The following is a description of a gene set: Human Gene Set: KRIGE_RESPONSE_TO_TOSEDOSTAT_24HR_DN from publication Krige D, Needham LA, Bawden LJ, Flores N, Farmer H, Miles LE, Stone E, Callaghan J, Chandler S, Clark VL, Kirwin-Jones P, Legris V, Owen J, Patel T, Wood S, Box G, Laber D, Odedra R, Wright A, Wood LM, Eccles SA, Bone EA, Ayscough A, Drummond AH (PMID 18701491) species: Homo sapiens Genes down-regulated in HL-60 cells (acute promyelocytic leukemia, APL) after treatment with the aminopeptidase inhibitor tosedostat (CHR-2797) for 24 h. CHR-2797 is a novel metalloenzyme inhibitor that is converted into a pharmacologically active acid product (CHR-79888) inside cells. CHR-79888 is a potent inhibitor of a number of intracellular aminopeptidases, including leucine aminopeptidase. CHR-2797 exerts antiproliferative effects against a range of tumor cell lines in vitro and in vivo and shows selectivity for transformed over nontransformed cells. Its antiproliferative effects are at least 300 times more potent than the prototypical aminopeptidase inhibitor, bestatin. However, the mechanism by which inhibition of these enzymes leads to proliferative changes is not understood. Gene expression microarrays were used to profile changes in mRNA expression levels in the human promyelocytic leukemia cell line HL-60 treated with CHR-2797. This analysis showed that CHR-2797 treatment induced a transcriptional response indicative of amino acid depletion, the amino acid deprivation response, which involves up-regulation of amino acid synthetic genes, transporters, and tRNA synthetases. These changes were confirmed in other leukemic cell lines sensitive to the antiproliferative effects of CHR-2797. Furthermore, CHR-2797 treatment inhibited phosphorylation of mTOR substrates and reduced protein synthesis in HL-60 cells, both also indicative of amino acid depletion. Treatment with CHR-2797 led to an increase in the concentration of intracellular small peptides, the substrates of aminopeptidases. It is suggested that aminopeptidase inhibitors, such as CHR-2797 and bestatin, deplete sensitive tumor cells of amino acids by blocking protein recycling, and this generates an antiproliferative effect. CHR-2797 is orally bioavailable and currently undergoing phase II clinical investigation in the treatment of myeloid leukemia., and this is the list of marker genes: YY1, IKBIP, ESF1 (ESF1 nucleolar pre-rRNA processing protein homolog), TOP1MT, TSR1, BAHCC1, SPRY1, FRG1HP, DIMT1, SEC11C, SLC39A10 (NCBI Gene Id 57181), BTBD7, SLC12A9, RRP9, BID, NAA15, CFL2, EEIG2, TENT5A, SYNGR2, RCC1, SUPV3L1, SLC7A6 (solute carrier family 7 member 6), SUMO1 (small ubiquitin like modifier 1), KANK1, NXT1, RPS6KA4, TRNP1, KNOP1, FOXF2, PRKACA, PPAN, NDUFAF4, PSEN2, FAM201A, ZNF696, RPL27A, PDCD11, DCXR, AP4B1, NOL6, ARHGDIA, DDX18, LYAR, NR1H3, PLEKHH1, BOLA3, PES1, IGFBP7, SLC36A4, NUP88, ZNF330, MAD2L1, COX7B, AGMAT, NAA20, ANKRD27, TPP2, MRPS34, DDX24, CENPM, NTHL1 (NCBI Gene Id 4913), RIDA, ABCE1, IPO4, UTP20, CDK6, CLN6, USP7, CDC42EP4, CALR, POLR2D, PRTN3 (proteinase 3), TBC1D1, USP19, LRRC34, ABCC4, POLR2E, MRPL57 (NCBI Gene Id 84533), PAK1IP1, GMDS, NUP160, ISG20L2, MPO, HIVEP3 (NCBI Gene Id 86368), DDX10, SENP3, THADA, JMJD8, CCT3, TREX2, ACSL5, DCTPP1, ZBTB16, TRMT5, DNAJB6, DHCR7, PNP, EBF3, MGAT4A, WDR35, KLHL23, TMEM97, CFAP97, MRPL36, MRI1, NDUFB10, ATG3, PRKCQ-AS1, CFDP1, PDAP1, LRP3, TOMM5, CORO7, MED4 (NCBI Gene Id 51757), PUS7, ATG7, SLC39A3, RNASET2, PEX5, PLA2G4A, ALDH5A1, HNRNPC, MYBBP1A, OXER1, NOP16, NUDT12, SERF2, HMGB1 (high mobility group box 1), WDR75, LRG1, CLPB, ERAP2, CTRL, ECI2, DDX31, HMGB1P4, TIMM50, HSPB1, TMEM177, GAS5, TRIP13, CLUH, SMARCD1, SLC2A5, NEU3, ZNRD2, ETFA, MSI2, PUM3, RIOX2, DEPTOR (DEP domain containing MTOR interacting protein), TCF4, SKP2, NUP35, TMEM70, JPT2, SAR1B, PEBP1, GM2A, COX16 (NCBI Gene Id 51241), TCF3, MARCKS, PTMAP3, BZW1 (basic leucine zipper and W2 domains 1), MRPL41, DOHH (deoxyhypusine hydroxylase), ZNRF3, PACRGL, TIMM22, PFDN6, FAM210A, MTFMT, GLYR1, C7orf50, EARS2, DLEU1, LAS1L, FAM204A, TSPOAP1, C19orf44, PRPS1, HSP90B1, NOLC1, NOP2, CUTC, ARMC10, SNHG5, ATL2, SORD, GLA, PPP2R5D, PSME3, PSMA2, NDUFS5, POLR1B, UBAP2L, FAM98A, SLC25A19, RAB32, PCCA-DT, EWSR1, SNHG4, BZW2, DPP7, RPL21P68, ACY1, QDPR, MOGS, SCRIB, SOD2, NAGPA, MATK, METTL26, ME2, SSBP4, ASB13, LPCAT1, SNHG26, CRELD1, EBNA1BP2, RANGAP1, IKZF1 (NCBI Gene Id 55429), NREP, GNPNAT1, TXNDC17, GADD45B, PARVB, ZNF74, KIF9, GAR1, RBM12, STK11, FGFBP3, PSMA7 (NCBI Gene Id 5688), CCDC26, EXOSC7, P2RY6, B3GNT7, RPAIN, ACTR3B, MYO10, RAD1, DHCR24, OVAAL, ATR, RPL22L1, HDAC4, ALKBH2, NOL10, MYC, ELANE, SFN, NDUFA11, CIAPIN1, NDUFS3, GEMIN5 (gem nuclear organelle associated protein 5), MRPS26 (NCBI Gene Id 81568), DCBLD2, RBM28, ZFP36L2, ADGRA3, TENT5C, RPL12P11, SLC19A2, GGA2, STING1, SRFBP1, POLD2, ATAD3A, SPTLC2, ZNF816, RPL5, ZNHIT2, DUSP23, DEPDC7, ATP5MC1, DHX37, RNGTT, VKORC1L1, AQR, PKP4, ATP23, SLC25A39, MRPL21, LY6E, ZMYND19, TARDBP, ZSCAN5A, CENPV, PHB1, HDGF, ACAT1, GEMIN4, RHOT2, NRGN, COPRS, PHACTR1, PRCP, TAF5L, MTCH2, MRPL24, SLC29A2, CEP43 (NCBI Gene Id 11116), NOC4L, CD81, PDCD2L, SERBP1, WDR12, GAL, TIMM21, COPB2, RRP1B, CKS2, TXLNG, ARK2N, HMGN5, PRDX1, MRTO4, PRMT5, POLR2H, TFRC, ANKRD36, SLC5A6, NME1, POLR3H, MAPKAPK5-AS1, DBR1, SRM, N6AMT1, LYRM2, SESN3, UTP15, POLR1F (NCBI Gene Id 378048), IMP4, HDAC2, CYB5A, TOR1AIP2, CFAP263 (NCBI Gene Id 92918), CWF19L1, ESYT2, TIMM23, PM20D2, MRPL12, PRR5, SQLE, CTSG, COQ3, IRX3, ELP1, TGS1, CLTB, LYZ, FBRSL1 (fibrosin like 1), DYRK2 (NCBI Gene Id 8445), LGALS14, EIF3J, EXOSC4, DDX19A, DANCR, PWP2, NLN, MRPS25, GPR85, DCAF4, L3HYPDH, MRPS12, MTHFD2L, SCO1, METTL16, NOC3L (NOC3 like DNA replication regulator), THAP4, NUP155, EPC2, RNASE2CP, HDDC2 (NCBI Gene Id 51020), CHST4, POLR2F, EI24, FSBP, NUDT4, ROPN1L (rhophilin associated tail protein 1 like), UPK3A, GTF2H2, SHPK, BEND3, IDH3B, C8orf33, ARMC8, FSCN1, TGIF2, ERCC2, ADRB2, PRR7, MRPL14, MIR17HG (miR-17-92a-1 cluster host gene), ZNF486, KCTD12, COPS7B, PRDX4, TOMM22, NDUFAB1, TWNK, ALDH18A1, SRSF11, HMGN3, DIXDC1, SCARB1, B3GALNT2, ANAPC5, CA2 (carbonic anhydrase 2), CENPW, TBL3, H1-2, IFT56, ASAH1, BDP1, LGALS9, SLC17A9, PNO1, HS3ST3B1, VAMP8, NFE2L3, PSMA5, ISOC2, FAM117B, SLC37A4, ZBTB24, SCAF11, MCM8, TMEM64, MPHOSPH6, MPZL1, G3BP1, MRPS30, HOXD13, HOMER1, LUC7L3, CCDC138, WDR74, COIL, BOLA2, TRAPPC2L, SLC25A12, CCDC169, SLC39A4, PRKACB (NCBI Gene Id 5567), ATP6V1E2, CLEC11A, MORN2, METTL21A, APTX, DNAAF3, ZNF667, ATOX1, KLHL18, BGLAP, ERGIC1, TMEM120B, TELO2, LTV1, SNRPF, VKORC1, CLPTM1L (NCBI Gene Id 81037), COX11, NAA25 (N-alpha-acetyltransferase 25, NatB auxiliary subunit), PALS2, ALG3, STK33, PRPF31, TIMM17A, HES6, GOLM1, FJX1, MT1F, XPO5, GALNT2, CREB3L2, SLC43A3, BCCIP, SLC25A30, UBA2, DEF8, UBIAD1, NAA10 (N-alpha-acetyltransferase 10, NatA catalytic subunit), PPP1R27, NOC2L, HDHD5, GNL3, EXOSC3, IMP3, UQCC3, KIF20B, TIMM8B, LPL, COX5A, RMND5B, RNF207 (ring finger protein 207), THOP1, B4GALT5, TIMM13, KTI12, RLIG1, HPDL, RFTN1, GRSF1, ILF3, DHX30, ZNF593, TPR, ATP11B, MIR3682, RITA1, C1QBP, TMEM201, FMNL2, AMD1, DHRS9, DCAF8, INSIG1, ZNF530, EBPL, LSS, PCOLCE2, RNASE3, NELFCD, FKBP4, NUDT7, FAM118A, IPMK, TRIAP1, SERF1A, SEC62, PPP2R2D, UBE2E2, PPIH, GFOD1 (Gfo/Idh/MocA-like oxidoreductase domain containing 1), SNRNP25, PPP4R3B, AKAP1, HNRNPA3P17, ABCF2, MIPEP, RNASEH1-DT, LLPH, SSB, UTP23, URB1, KBTBD6, NPM3, UAP1, POLR1A, SNHG12, PXN-AS1, DLX4, FAS, CYB561, CCDC85B, GNL3L (G protein nucleolar 3 like), NICOL1, EIF3B, TAF4B, DKC1, MREG, MFNG, NUP62, SETD4, FABP5, PRKAR2B, MROH1, AK6, SACS, FASN, SLC29A1, SCO2, ZNF618, TFEC, JPT1, TUBGCP4, MANEA, FUT4, GPD1L, WDR46, GRPEL1, WT1, EEF1AKMT4, PTGER4, TUBA3E, PMVK, TOMM6, STOM, MS4A3, GRAMD4, SFXN4, NCR3LG1, UMPS, FLT3, COL4A2, UNC93B1, ZDHHC11, C4orf3, NAXE, DUS3L, NOPCHAP1, GJA3, RBM25, ITM2A, RPP40, TMEM50B, GLRX5, DCUN1D5, ENAH, TNFSF13B, SPR, HILPDA, LDLRAD3, ZSCAN31, C9orf78, HS3ST3A1, MTPAP, FAM118B, RBBP6, UBASH3B, YBX3, PSMG4, CWC25, SMIM30, IGSF10, NCBP2, DDX46, PRG2, AK4, ABCC5, HNRNPD-DT, POLR1G (NCBI Gene Id 10849), RRP15, IL17D, PALM2AKAP2, RRP12, B3GAT3, ZNF574, PRMT3, H2BC7, MIF, MTFP1, SNU13, GCAT, TMED3, TFAM, CARNMT1, HSPE1, POP1, PPP1R14B, BMP8B, FARP2, DCAF13 (DDB1 and CUL4 associated factor 13), POP7, PGAM5, HIVEP2, SCAMP1, DDX54, EIF4E, CEBPA, CHMP1A, NPRL2, DHX33, HEATR1, ABCB10, SLC25A10, POLR1C, PSMC2, BCL11A, LDHA, IL6R, RRP7A, PIAS2, ENDOG, COLGALT2, CA8, NR2F2, RABL2B, IDH3A, P2RY2, RCL1, ZEB2, AZU1, SCLY, SEH1L, PTMA, GOT2, LARP4, B4GAT1, AURKAIP1, PRRC2C, PWWP3A, DUT, SLC38A5, CD59, CABLES1, SCFD2, ACADSB, NDUFB7, GNB4, MTURN, DFFB, NUFIP1, LBHD1, NDUFAF8, GALNT14, TASP1, DAZAP1, PGK1, ADISSP, SLC39A14 (NCBI Gene Id 23516), SLC40A1, SRGN, ARHGDIG, ELP2, HSP90AA1, DTD2, PIGW, TRIM14, PIH1D2, P2RY8, SYNCRIP, LRPPRC, CCDC86, RALGAPA2, ANKS6, WDR43, ADAM15, AKT2, MCAT, INF2, ANKMY1, MLLT6, TFDP1, COPS9, RPS26, ASXL1, VDAC1, GSPT1, KHSRP, RBFA, CHCHD7, SNRPA1, SCD, TIMM10, TEX261, NOP14, ALMS1, HSPA1B, RDH10, ATP5MC3, RPIA, RANBP1, LGALS12, GPATCH4, MLC1, TMEM109, ALG1, GEMIN6, DNAJB1, FAM136A, MRPL4, FKBP1A, NOP9, DLEU2 (deleted in lymphocytic leukemia 2), BAG1, EIF4E2, DNAAF2, LYST, PRMT1, RABEPK, TET1, SFXN1, STRBP, TXNL4A, SPRYD4, ALDH1B1 (aldehyde dehydrogenase 1 family member B1), SLC2A1, CD320, HSPA4L, NOP56, NIFK, PPARGC1B, RAD18, WDR4, MAZ, SKIC8, SLC16A1, ARL4A, RNF126, SLC35G1, ATP5ME, SYNGR1, SLC19A1, ACOT7, COA7, IFRD2, CLPTM1, MDFIC, TRMT10C, FBL, SOX4 (NCBI Gene Id 6659), TMEM147, PCID2, MPI, PRPS2, METTL8, MRPL23, NOCT, NANOS1, ERI3, IPO7, ACP3, SFPQ, TRIB1, AIF1, DNAJA1, WDR3, GADD45GIP1 (NCBI Gene Id 90480), TJP2, TNPO2, DUSP3, ATP5MF, RUVBL2, PLD6, SSBP3, CHORDC1, PDE4A, ZNF692, UBL5, MSH6, PFAS, PMPCA, SIVA1 (NCBI Gene Id 89639), MAP2K3, PISD, MRPS17, LINC00926, QTRT1, GBA1, TBC1D22A-DT, NUDC, CENPX, DDX21, LSM7, FAM162A, BDH1, HNRNPD, MRPL44, PLAAT1, EMC8, TMF1, STIP1, VARS1, NEFH, PEMT, FXN (frataxin), FCGR1A, CHML, PTGER2, DNAAF5, ZNF438, HMOX2, SEPTIN7, TRMT10A, MMACHC, PRXL2B, HSPD1, GTF2H1, ARRB1, ACTR5, TMEM68, TMED4, UCK2, RFK, NASP, RFESD, WDR77, TSR3, ATAD3B, NUB1, RIOK1, SLAMF8, NME4, GTPBP4, GRWD1, APBB2, TGFBRAP1, CYB5D1, CCND1, FTSJ1, MYO19, RHOF, CYB5RL, DRAM1, ARL17A, ABCD3, DPH2, LUC7L, DEAF1, NRROS, DNAJC11, DHODH, UNC13B (unc-13 homolog B), ATF7IP2, RPGRIP1L, MLKL, HNRNPA3, NUDT5, DNAJC12, HSPBP1, MED24, KPNA5, RDH13, ZNF641, MICOS13, ISCA1, MYB, CFAP73, ADAT2, FZR1, TBC1D4, GPS2, HNRNPDL, FAM229B, TPM3, TRG-AS1, RBM26, EXOSC5, MRPL16, SDF2L1, FLVCR1, EIF5B, TRMU, PA2G4, MT1X, TOMM40, WDR90, FOXRED2, EIF3M, TUBB2A, TRAP1, DEFA1, DDIAS, ECE2, NCL, GOLGA8N, NIP7, ITGA4, CCDC124, DNAJA4, SMC4, GFM1, NHP2, AHSA1, DACH1, PDCD5, SLIRP, RUVBL1, ALYREF, ADI1, IKZF5, DHX57, EEF2K, AGPS, MYLIP, RSC1A1, PIGL, HSPH1, TTLL12, L3MBTL2, LAPTM4B, SLC25A32, SNHG16, SNHG14, BOP1, NAA38, PA2G4P2, FARSA (NCBI Gene Id 2193), ERICH1, MGLL, IFITM2, GCSH (NCBI Gene Id 2653), SPART, IFT57, TFB2M, ELOF1, ARL5A, TM7SF3, CD302, KITLG, FAM174C, SORL1, BYSL, PWP1, SLFNL1, PROSER2, TMEM150C (NCBI Gene Id 649616), FUBP1, NHP2P2 (NCBI Gene Id 442290), RRP1, DDI2, PAFAH1B2, MRPS23, ATP5F1D, TTC5, SNRNP70, MON1A, TRAFD1, MACROH2A1, EGR1, UBE2NL, GPR183, ANTKMT, CETN2, CEACAM6, ZAR1, WDR36, NR1D2, LPCAT2, SLC11A2, EEF1AKMT1, SRRT (serrate, RNA effector molecule), PTGES2, PHACTR3, ANKLE1, POLR3G, PTMAP4 (NCBI Gene Id 5761), PRADC1, TCOF1, CSKMT, NOL11, RRS1, NCLN, HK2-DT, DPCD, EBP